The following is a description of a gene set: species: Homo sapiens Throughout the cell cycle, the genome is constantly monitored for damage, resulting either from errors of replication, by-products of metabolism or through extrinsic sources such as ultra-violet or ionizing radiation. The different DNA damage checkpoints act to inhibit or maintain the inhibition of the relevant CDK that will control the next cell cycle transition. The G2 DNA damage checkpoint prevents mitotic entry solely through T14Y15 phosphorylation of Cdc2 (Cdk1). Failure of the G2 DNA damage checkpoint leads to catastrophic attempts to segregate unrepaired chromosomes. part of: G2/M Checkpoints Reactome Pathway: G2/M DNA damage checkpoint, and this is the list of marker genes: H2BC11, CDK1, BLM, H2BC21, WEE1, RPA3, H2BC4, TP53BP1, BARD1, ATM, ATRIP, RNF168, TOP3A, TP53, CHEK2, NSD2, RHNO1, BABAM1, YWHAQ, CCNA1 (NCBI Gene Id 8900), RFC4, RMI2, H2BC14, MDC1, HERC2, H2BC3 (H2B clustered histone 3), CHEK1, RPA1, H2BC26, H2AX, RAD17, DNA2, RAD9B, UBE2V2, RFC5, H3-4, BABAM2, BRIP1, ATR, RMI1, BRCC3, ABRAXAS1, BRCA1, NBN, YWHAH, RPA2, YWHAG, HUS1, MRE11, YWHAE, H2BC9, CCNA2, CDC25C (NCBI Gene Id 995), RFC2, YWHAB, H2BC17, CCNB1, YWHAZ, RAD9A, H2BC12, SFN, H2BC12L, RAD1, RNF8, RAD50, H2BC13, TOPBP1, H4C1, UBE2N, EXO1, WRN, UIMC1, RBBP8, H2BC5, KAT5 (NCBI Gene Id 10524), RFC3 (replication factor C subunit 3), PIAS4, H2BC1, H2BC15